The following is a description of a gene set: Human Gene Set: GSE38304_MYC_NEG_VS_POS_GC_BCELL_UP Germinal centers (GC) arise within B cell follicles upon antigenic challenge. In the dark zones (DZ) of GCs, B cells proliferate and hypermutate their immunoglobulin genes, and mutants with increased affinity are positively selected in the light zone (LZ) to either differentiate into plasma and memory cells, or re-enter the DZ for further refinement. However, the molecular circuits governing GC positive selection are not known. Here, we show that the GC reaction requires the biphasic regulation of c-MYC expression, involving its transient induction during early GC commitment, its repression by BCL6 in DZ B cells, and its re-induction in a subpopulation of positively selected LZ B cells destined to DZ re-entry. Accordingly, acute disruption of MYC function in vivo leads to GC collapse, indicating an essential role in GC physiology. These results have implications for our understanding of GC selection and the role of MYC deregulation in B cell lymphomas. We used microarrays to determine the global gene expression programs that distinguish MYC+ GC B cells from their MYC- negative counterparts. studied in species Homo sapiens Genes up-regulated in germinal celter B lymphocytes: MYC- versus MYC+. from publication Dominguez-Sola D, Victora GD, Ying CY, Phan RT, Saito M, Nussenzweig MC, Dalla-Favera R (PMID 23001145), and this is the list of marker genes: RNF130 (ring finger protein 130), MRGBP, MYL4, CD3G, TNIK, PDZD4, PLXND1, IFT80, GATA1 (GATA binding protein 1), GDPD3, EGR2, TMIGD1, RAB3IP, TNS1, MYO6 (NCBI Gene Id 4646), KIAA0040, EGR3, MAGI3, MARCKSL1, CHDH, SQOR, BCL9, SMARCA2, STAG2, TPCN2, EEF2K, ZDHHC17, BAZ2B, DAPL1, IFNGR2, DAPK1, BRDT, EMID1, CABYR, ST3GAL5, ETS2, ARHGAP29, TBL1X, AMIGO2, CREB1, ADGRL1, KMT2D, PACSIN1, CERS6, RASL11B, HECTD2, LRRC42 (leucine rich repeat containing 42), NR4A3, INPP4A, TRIB2, CCNG2, LZTFL1, DHX40, TSPAN32 (NCBI Gene Id 10077), MED13, BBS9, ZCCHC12, LDHAL6B, CSPP1, LATS1, NAB2 (NGFI-A binding protein 2), RAMP1, CD163, PTP4A3, MARCKS, IRF7, PDE4B, CNN3, ATP11B, GTF2IRD1, SSBP2, ACVRL1, GBP7, SMC6, LYNX1, ALMS1, GALNT6, STT3B, PMEPA1, MTSS1, PHF14, ITGB3, SETX (NCBI Gene Id 85506), IL6ST, CDKN2D, CA2, GYPC, ZNF22, ADCY6, IL17RB, PAK1, SUOX, IFNAR1, ZBTB34, CERT1, TTC3, N4BP2, TIMP2, DNTT, CD2AP, CD46, R3HDM1, BRWD1 (NCBI Gene Id 54146), CAMK4, GSE1, SIAH1, ZBTB37, ZDHHC14, ZFYVE21, FOXO3, TBCEL, PLEK2, PTCH1, MYO10 (myosin X), RNF167 (NCBI Gene Id 26001), CARD6, CLEC16A, DIP2C, CHD3, VANGL2, MEF2A, H3C14 (H3 clustered histone 14), STMN1 (stathmin 1), MAP4K3 (NCBI Gene Id 8491), TET1, PARD6G, S100PBP, BACH2, ALS2CL, CENPJ, GZMA, TUBB2B (tubulin beta 2B class IIb), IL2RA, ZCCHC24, H2BC13, CHST15, ART4, BIRC3, PDLIM4, AMPD1, PGGT1B (NCBI Gene Id 91374), NPC1, LRRC1 (leucine rich repeat containing 1), MBTD1, SMC4, SALL2 (NCBI Gene Id 6297), ITM2A, CCR9, DYRK2, EPHX1, SELENOP, IFT25, SLC16A10, TMCC3 (transmembrane and coiled-coil domain family 3), ID3, KIF23, NR3C1, BEND5, PLSCR3 (NCBI Gene Id 57048), HSDL1, RBM38, SUV39H1, CDKN2C, SSH2, IL4R, SH3PXD2A, ANKRD50, NDRG1, FRMD6, TOP2B, ZNF281, NFRKB, SORCS2, PTGIR, ATP8A1 (NCBI Gene Id 10396), RFTN1, IGFBP4, ARL5B, IGSF23, TMIE, ANKRD13B, PIK3C2A, TRIM56, KCNMB4, RASGRF2, PPP1R3F, TRIM59, ST8SIA1, SGK3, CTNNBL1, GGT1, IFIT3, ECM1, ARID3B, PPP1R3B, RTF1, SHE, RALGPS2, TMEM108, SLFN5